The following is a description of a gene set: Human Gene Set: GOBP_TELOMERE_TETHERING_AT_NUCLEAR_PERIPHERY The process in which a telomere is maintained in a specific location at the nuclear periphery. studied in species Homo sapiens, and this is the list of marker genes: TERB2, TERB1, NUP98, MAJIN, SUN1, SPDYA